The following is a description of a gene set: Human Gene Set: REACTOME_OAS_ANTIVIRAL_RESPONSE OAS antiviral response species: Homo sapiens, and this is the list of marker genes: RIGI, RNASEL, PDE12, ABCE1, FLNA, OASL, OAS2, OAS1, OAS3